The following is a description of a gene set: Reactome Pathway: Transcriptional regulation by RUNX2 This event has been computationally inferred from an event that has been demonstrated in another species.<p>The inference is based on the homology mapping from PANTHER. Briefly, reactions for which all involved PhysicalEntities (in input, output and catalyst) have a mapped orthologue/paralogue (for complexes at least 75% of components must have a mapping) are inferred to the other species. species: Mus musculus part of: Generic Transcription Pathway electronically inferred by orthology from the curated human pathway, and this is the list of marker genes: Runx2, Psma5 (NCBI Gene Id 26442), Ppm1d, Rps27a (ribosomal protein S27A), Psmc6, Ar, Psma4, Cdk4, Psmb5, Psma3, Psmc5, Psmd7, Psmd1, Psmc3, Psmc1, Psmd6, Psmc2, Psma7, Psmd12, Psmd13 (proteasome (prosome, macropain) 26S subunit, non-ATPase, 13), Cdk1, Ubb, Psma6, Psmb7, Smad1, Psmb4, Ccnb1 (cyclin B1), Psmb6, Cbfb (NCBI Gene Id 12400), Psmc4 (NCBI Gene Id 23996), Psma2, Psma1, Cul1, Ccnd1